The following is a description of a gene set: Human Gene Set: GOBP_RESPONSE_TO_MUSCLE_ACTIVITY Any process that results in a change in state or activity of a cell or an organism (in terms of movement, secretion, enzyme production, gene expression, etc.) as a result of a muscle activity stimulus. species: Homo sapiens, and this is the list of marker genes: SELENON, FN1, PRKN, ABCG5, SLC38A2, MYOG, PERM1, FNDC5, COL6A1, CAPN3, ATP5F1A, METRNL, PRKAA2, ITGA5, RYR2, ADSS1, AGT, TNS2, SLC7A5, MIR762, RBP4, ITGA2, DAG1, POSTN, HIF1A, MSTN, SRD5A1, ADSL, ABCG8, PPARGC1A, ITGB1, FIS1, PRKAG3